The following is a description of a gene set: studied in species Mus musculus Mouse Gene Set: REACTOME_SODIUM_PROTON_EXCHANGERS Sodium/Proton exchangers, and this is the list of marker genes: Slc9a9, Slc9a3, Slc9a5 (solute carrier family 9 (sodium/hydrogen exchanger), member 5), Slc9a7 (solute carrier family 9 (sodium/hydrogen exchanger), member 7), Slc9a1, Slc9a4, Slc9a2, Slc9a8, Slc9a6